The following is a description of a gene set: Genes up-regulated in bone marrow-derived macrophagesat 45 min stimulation of IL10 and LPS: wildtype versus IL6 knockout. from publication El Kasmi KC, Holst J, Coffre M, Mielke L, de Pauw A, Lhocine N, Smith AM, Rutschman R, Kaushal D, Shen Y, Suda T, Donnelly RP, Myers MG Jr, Alexander W, Vignali DA, Watowich SS, Ernst M, Hilton DJ, Murray PJ (PMID 17114459) studied in species Homo sapiens Human Gene Set: GSE5589_WT_VS_IL6_KO_LPS_AND_IL10_STIM_MACROPHAGE_45MIN_UP IL-10 or IL-6 stimulation of control 129xC57BL/6 murine bone marrow derived macrophages in the presence of LPS. We used microarrays to detail the global programme of gene expression changes in response to IL-6 or IL-10 stimulation in the presence of lipopolysaccharide. BMDMs were isolated from control, IL-6-/-, and IL-10-/- mice on a 129XBL/6 mixed background mice and differentiated in the presence of CSF-1 for 6-7 days. Cells were scraped and plated in 6 well plates at 2x10e6/well. Cells were washed with complete DMEM and rested for 1-2 hr before stimulation with combinations of IL-10 (10 ng/ml), IL-6 (2 ng/ml) or LPS (100 ng/ml) for 45 min or 180 mins. Complete biological replicates were performed., and this is the list of marker genes: KIF22, CFAP410, RASGEF1B, SLC43A3, SART3, SPC24, PDLIM2, VBP1, SLC44A2, TRAPPC1, PKIB, DPY19L1, CELA1, POR, WBP11, PTS, VAV1, MTMR11, GAPVD1 (GTPase activating protein and VPS9 domains 1), DNAJC7, KIF18B, MAGEE1, COX7A2, KCNE3, CCND3, ENTREP3, CENPW, VPS33A, NCBP2AS2, MCEE, IL18, TUBGCP6, CBX6, CPSF1, SH3BP5L, GEN1, BCL9L, DENND2C, PRKACB, LTF, CIP2A, BPHL, PKP4, NDC80, MFSD13A, DFFA, DDX47, CITED2 (NCBI Gene Id 154106), CENPI, MSTO1, NME7, OLFM4, SMC1A, STK4, SGCB, RHOA, CENPT, OSBPL1A, WNK3, C8orf58, PXK, IRAK1BP1 (NCBI Gene Id 80793), PARPBP, SCARB1, NEDD4L, PIMREG, CHTF18, VAMP3, DSCC1, ANAPC5, SPC25, NPY, UBQLN2, PABIR2, PNPO, LAGE3, CCP110, SLC2A8, NRM, RAP2A, GPR176, STIL, DOCK5, CLTA, LRRC45 (NCBI Gene Id 201255), PCNT, G2E3, TPX2, MRPL28, NUAK1, ZNF808, UGCG (NCBI Gene Id 7357), RDH11, POLE, RAB3GAP1 (RAB3 GTPase activating protein catalytic subunit 1), REXO5, TLE6, SNAPC4, SERPINE2, TRPV2, WWP2, TONSL, TUBA4A, CYFIP2, UAP1L1, H1-0 (H1.0 linker histone), KNTC1, SLC39A8, ZKSCAN5, JPT2, HJURP (Holliday junction recognition protein), PLD2, ESCO2, BRCA1, AURKA, NKIRAS2, UQCC5, CENPH, PPCDC, SYCE2, MPND (MPN domain containing), UPF2, ZFAND2A, ADCY2, COMMD9, ERLIN1, NDUFA4, TLR2, KNSTRN, CDK14, FBXO10, SUV39H1 (SUV39H1 histone lysine methyltransferase), PDZK1IP1, PARK7, DDB1, ESPL1, LMNB1, MSS51, SERPINB6, FAM217B, BRIP1, NAT8L, DYNC2LI1, EI24, ARL8B, SF3B1, ERI2, CDCA5, GCAT, MGAT4A, SUPT7L, NUDT21, HNRNPA3 (NCBI Gene Id 220988), RAB42, DKK2, FAM72A, PRKRA, TSC22D4, TMEM273, NF2, LRRK2, CENPP (centromere protein P), ABCD4, TTK, SELENOK, ATP2A3, EBPL, ABCC4, TMEM101, TK1, CALR, TRAPPC10, FGD3, PLK4, DBF4, GLOD4, CEP192, PPM1F, HASPIN, KIF18A, CENPQ, UBE2T, RFNG, PCIF1, CIBAR1, UEVLD, RAD51AP1, FAAP20 (FA core complex associated protein 20), EPB41L3, MIS18A, DIAPH3, DOCK10, NCAPH, TMEM141, P2RY12, SPP1, GAS2L3, ZC3H4, SORBS3, CENPO